The following is a description of a gene set: Src is believed to suppress gap junction communication by phosphorylating Cx43. The kinases c-Src, PKc and MAPK play an essential role in the phosphorylation of Cx which leads to its degradation. c-Src appears to associate with and phosphorylate Cx43 leading to closure of gap junctions. Evidence suggests that v-src may activate MAPK, which in turn phosphorylates Cx43 on serine sites leading to channel gating. studied in species Homo sapiens Reactome Pathway: Regulation of gap junction activity part of: Gap junction trafficking and regulation, and this is the list of marker genes: GJA1, E, SRC, TJP1